Given this list of marker genes Brca1, Slc16a1, Ptgr1, Pafah1b3, Cycs, Lmnb1, Ccnb1, Uck2, Slc25a51, Idh2, Psmc1, Lxn, Dgcr6, Desi1, Dntt (NCBI Gene Id 21673), Rag2, Hes6, H2az2, Prep, Kif2c, Vpreb3, Myl4, Stmn1, Gpam, Cdc25c, Rrm2, Rgs2, Tax1bp3, Nudt1, Cd93, Prps1, Zfpm1, Plin2, Zbed3 (zinc finger, BED type containing 3), Ncbp2, H2az1, Rnaseh2b, Cox7a2, Mpp1, Txn1, Mthfd2, Sox4, Cdkn3, Capn2, Ewsr1, Cdc45, Prdx4, Hmga1, Gas7, Ufc1, Rag1, Marcks, Il7r, Snrpc, Snrpb, Cks1b, Pgls, Notch1, Mcm5, Psmd8, Ndufc1, Gfra1, Dhfr, Litaf, Ccnb2, Ezh2, Smarca4, Gm4739, Lgals9, Ccnd3, Nek2, Myb, Pla2g12a, Anln, Enpep, Gm4870 (predicted gene 4870), Irag2, ENSMUSG00000137801, here is a description of the gene set: from publication Mori S, Rempel RE, Chang JT, Yao G, Lagoo AS, Potti A, Bild A, Nevins JR (PMID 18922927) Down-regulated genes in the B lymphocyte developmental signature, based on expression profiling of lymphomas from the Emu-myc transgenic mice: the mature B The Emu-myc transgenic mouse has provided a valuable model for the study of B-cell lymphoma. Making use of gene expression analysis and, in particular, expression signatures of cell signaling pathway activation, we now show that several forms of B lymphoma can be identified in the Emu-myc mice associated with time of tumor onset. Furthermore, one form of Emu-myc tumor with pre-B character is shown to resemble human Burkitt lymphoma, whereas others exhibit more differentiated B-cell characteristics and show similarity with human diffuse large B-cell lymphoma in the pattern of gene expression, as well as oncogenic pathway activation. Importantly, we show that signatures of oncogenic pathway activity provide further dissection of the spectrum of diffuse large B-cell lymphoma, identifying a subset of patients who have very poor prognosis and could benefit from more aggressive or novel therapeutic strategies. Taken together, these studies provide insight into the complexity of the oncogenic process and a novel strategy for dissecting the heterogeneity of B lymphoma. studied in species Mus musculus Mouse Gene Set: MORI_MATURE_B_LYMPHOCYTE_DN